Given this list of marker genes PLCZ1, PKD1, PLCL1, PLCD3, PLCD1, GNA11, PLCH1, PLCB1 (NCBI Gene Id 23236), PLCB2, PLCE1, PLCG1, FFAR1, ITPR3, PLCB3, PLCG2, here is a description of the gene set: GPR40 role in insulin secretion Human Gene Set: WP_GPR40_ROLE_IN_INSULIN_SECRETION studied in species Homo sapiens